Given this list of marker genes CEP68, ZNF131 (NCBI Gene Id 7690), ING1, MKNK2, MCL1, NUDT4, ACSL3, EMP2, SVIL, ETV5, SLC5A3, FAIM, GLIPR1, CUX1, INSIG1, SIKE1, B4GALT1, RAB22A, NFATC2IP, JADE1, NOTCH1, ITGA5, VPS35, RHOQ, HTATIP2, TRAF4, IDH1, PITPNA, BAZ1A, ZBTB5, DYRK2, PHIP, CDC42EP1, NDUFB2, HMBOX1, GLG1, VCAN, OTUD4 (NCBI Gene Id 95936), ENAH, CDC42EP4, PNRC2, BACH1, PCNA, PCLO, IL11, RPRD2, AP1G2, ZFP69B, WWC2, PPP1R12A, STK11, ALDH3A2, KMT2A, CDK2, CAPN7, SEMA4C, KDM2A, CSGALNACT1, TCF20, IL7R, FBRS, ADAM17, CDH12, F8A1, OBSL1, PTGS2, DLG5, SV2A, ZCCHC24, FABP4, NINJ1, SPAG9, FZD2, HLA-G, NR3C1, TMEM135, WNT5A, RGS1, CSNK1E, GFPT1 (NCBI Gene Id 2673), NUP210, ARHGAP12, PTPN12, EXT1, SHC1, MGAT2, U2SURP, GABRA2, SCHIP1, JAG1, TMEM51 (transmembrane protein 51), S100A4, HDAC9, DDIT3, ETS2, MAP3K11, KCNK1, ERAP1, TCAF1, ZMIZ2, SMURF1, IGFBP5, HHEX, SDCBP, HLA-B (NCBI Gene Id 730410), LGALS8, UBR2, TRIM24, BTG1, LIMCH1, MAFG, FOSL2, NCOA2, RBM19, PRKD1, TCF4, HOXA9, CD82, GTPBP4, PNP, MYO1C, CBX4, HMGCR, GET1, MCM6, EHD3 (NCBI Gene Id 30845), CKLF, BRD3OS, DUSP5, BCL3, FOXC1, KLRC3, CTDSPL, SH3BP5, STX4, TGIF1, GOLPH3L, FBXL5, MAP7D1, MBP, TCP1, DERL2, DIO2, ACACA, CCNL1, KLF10, SS18 (NCBI Gene Id 6760), SATB2, TMEM97, GABARAPL1, WIZ, SYNM, CCN1, SERPINE2, CCDC85B, PMAIP1, THYN1, LARP1, HOXA10, KDM6B, SOS1, ARL4C, ATP2B1, ZMYND8, KCNMA1, SEC24A, TNFRSF11B, MID1, PPP1R15A, PPM1F, EVA1B, RET, MSMO1, DLST, MNS1, FOS, AFF1, SLC9A6, TMT1A, ATF3, UBE2J1, MYO1B, IKBKE, NXF1, AGRN, CRK, CAV1, MBD4, MYO10, NKTR, SNX2, PAQR4, NCALD, TUT7, ELOVL6, EGR1, C2orf42, PBX1, NEO1, MLXIP, KAT6B, SLC7A1, SEC24D, TUFT1, ARID4B, TMEM87A, PSD3, SKP2, CD59, ITSN2, STK17A, RAP2C, DHFR, NAV3, ACOX1 (NCBI Gene Id 8308), MTHFD2L, SSBP2, YIPF5 (Yip1 domain family member 5), JRK, MECOM, PTPRK, MAP4K4, ZFP36, FOXO3, here is a description of the gene set: Human Gene Set: PHONG_TNF_RESPONSE_VIA_P38_COMPLETE from publication Phong MS, Van Horn RD, Li S, Tucker-Kellogg G, Surana U, Ye XS (PMID 20516219) species: Homo sapiens Genes whose expression changes in Calu-6 cells (lung cancer) by TNF were blocked completely by p38 inhibitor LY479754. p38 mitogen-activated protein kinase (MAPK) is rapidly activated by stresses and is believed to play an important role in the stress response. While Chk1 is known to mediate G(2) DNA damage checkpoint control, p38 was also reported to have an essential function in this checkpoint control. Here, we have investigated further the roles of p38 and Chk1 in the G(2) DNA damage checkpoint in cancer cells. We find that although p38 activation is strongly induced by DNA damage, its activity is not required for the G(2) DNA damage checkpoint. In contrast, Chk1 kinase is responsible for the execution of G(2) DNA damage checkpoint control in p53-deficient cells. The inhibition of p38 activity has no effect on Chk1 activation and gamma-H2AX expression. Global gene expression profiling of cancer cells in response to tumor necrosis factor alpha (TNF-alpha) revealed that p38 plays a strong prosurvival role through the coordinated downregulation of proapoptotic genes and upregulation of prosurvival genes. We show that the inhibition of p38 activity during G(2) DNA damage checkpoint arrest triggers apoptosis in a p53-independent manner with a concurrent decrease in the level of Bcl2 family proteins. Our results suggest that although p38 MAPK is not required for the G(2) DNA damage checkpoint function, it plays an important prosurvival role during the G(2) DNA damage checkpoint response through the upregulation of the Bcl2 family proteins.